The following is a description of a gene set: Binding to D-enantiomers of glucose. studied in species Mus musculus Mouse Gene Set: GOMF_D_GLUCOSE_BINDING, and this is the list of marker genes: G6pdx, Hk2, Gck (NCBI Gene Id 14624), Pygl, Gyg1, Hkdc1, Hk3, Gys1, Gys2, Hk1, Slc2a8, G6pd2 (glucose-6-phosphate dehydrogenase 2), Ugp2, Slc2a3